Given this list of marker genes Fer, P2ry12, Abi3, Parvb, Abi2 (NCBI Gene Id 98436), Carmil1, Vil1, Atp7a, Aqp1, Phpt1, Actr3, Cd44, Akirin1, Wasf3, S1pr1 (NCBI Gene Id 99736), Whamm, Snx2, Pdpn, Ablim3, Plekho1, Nup85, Dnm2, Src, Actr2, Clrn1, Auts2, Arpc5, Spef1, Hrg, Hsp90aa1, Plxnb3, Ccdc88a, Coro1c, Fscn1, Spata13, Arpin, Slit2, Pmp22 (peripheral myelin protein 22), Arhgef4, Mstn, Rreb1, Cdc42, Ptpro, Mtor (mechanistic target of rapamycin kinase), Vav3, Snx1, Frmd7, Wasf2, Cttn, Arhgef7, Wnt1, Ajuba, Kank1 (KN motif and ankyrin repeat domains 1), Brk1, Cfl1, Twf2, Nck1, Golph3, Pxn, Carmil2, Cyfip1, Rac1 (NCBI Gene Id 52352), Sh2b1, Mtss2, Plce1, Nck2, Myo9b, Vcl, Enpp2, Fgd4, Hdac4, Pik3r1, Arpc2, Avil, Rac2, Abi1, Was, Ablim2, Dmtn, Kit, Rhod, Vav2, Ablim1, Epha2, Arhgef6, Itgb1, Cdh13, Twf1, Bin3, Coro1b, Wasf1, Nckap1, Capzb, here is a description of the gene set: A process that is carried out at the cellular level which results in the assembly, arrangement of constituent parts, or disassembly of a lamellipodium. A lamellipodium is a thin sheetlike process extended by the leading edge of a crawling fibroblast; contains a dense meshwork of actin filaments. Mouse Gene Set: GOBP_LAMELLIPODIUM_ORGANIZATION species: Mus musculus